The following is a description of a gene set: Any process that modulates the frequency, rate or extent of leukocyte adhesion to vascular endothelial cell. studied in species Mus musculus Mouse Gene Set: GOBP_REGULATION_OF_LEUKOCYTE_ADHESION_TO_VASCULAR_ENDOTHELIAL_CELL, and this is the list of marker genes: Ccl21d, Fut7, Chst2, Gcnt1, Elane, St3gal4, Ccl21f, Capn1, Nfat5, Rela, Gp1ba, Ptafr, Pawr, Selp, Itga4 (integrin alpha 4), Ccl21b, Sele, Irak1, Ccl28, Traf6, Itgb2, Zdhhc21, Ccl25, Rhoa, Il6, Alox5, Mdk, Tnf, Cxcl12, Ccl21e, Ccr2, Fut4, Ccl21a, Icam1, Chst4, Ets1, Klf4, Fut9